The following is a description of a gene set: Mouse Gene Set: GOBP_TENDON_DEVELOPMENT studied in species Mus musculus The process whose specific outcome is the progression of a tendon over time, from its formation to the mature structure. A tendon is a fibrous, strong, connective tissue that connects muscle to bone or integument and is capable of withstanding tension. Tendons and muscles work together to exert a pulling force., and this is the list of marker genes: Col11a1, Gdf7, Scx, Col5a1, Bmp4, Nr5a2, Comp, Mkx (mohawk homeobox)